Given this list of marker genes ARPC1B, ACTR3, ARPC2, ACTR2, WIPF1, WIPF3, WASL, NCK2 (NCK adaptor protein 2), ARPC4, ACTG1, ARPC5, ARPC5L, ACTB, ARPC1A, ARPC3, NCK1, WIPF2, here is a description of the gene set: Escherichia Eae/Tir to Actin signaling pathway. Pathway ID: N01092. Pathway type: Pathogen. Pathway class: nt06135 Cytoskeletal regulation (viruses and bacteria). Pathway Definition from KEGG: Eae -> Tir -> NCK -> (WASL+WIPF) -> ARP2/3 -> (ACTB,ACTG1) species: Homo sapiens Human Gene Set: KEGG_MEDICUS_PATHOGEN_ESCHERICHIA_EAE_TIR_TO_ACTIN_SIGNALING_PATHWAY